The following is a description of a gene set: Mouse Gene Set: GOCC_TERTIARY_GRANULE A secretory granule that contains cathepsin and gelatinase and is readily exocytosed upon cell activation; found primarily in mature neutrophil cells. studied in species Mus musculus, and this is the list of marker genes: Stx7, Stxbp2, Adam8, Cd177, Vamp1, Stxbp3, Slc11a1